Given this list of marker genes CA5A, ALDH18A1, OTC, PNPO (pyridoxamine 5'-phosphate oxidase), SLC25A13, ASL, ATP5F1A, CPS1, ARG1, ASS1, here is a description of the gene set: studied in species Homo sapiens Abnormal circulating arginine concentration Any deviation from the normal concentration of arginine in the blood circulation. Human Gene Set: HP_ABNORMAL_CIRCULATING_ARGININE_CONCENTRATION